The following is a description of a gene set: Human Gene Set: KEGG_MEDICUS_REFERENCE_HEDGEHOG_SIGNALING_PATHWAY_HH_LIGAND_SECRETION Hedgehog signaling pathway, HH ligand secretion. Pathway ID: N01537. Pathway type: Reference. Pathway class: nt06501 HH signaling. species: Homo sapiens Pathway Definition from KEGG: HHAT -> HH -- DISP1 >> SCUBE2 -> HH(extracellular), and this is the list of marker genes: SCUBE2, HHAT, IHH, DHH, DISP1 (NCBI Gene Id 84976), SHH